The following is a description of a gene set: from publication Lund R, Aittokallio T, Nevalainen O, Lahesmaa R (PMID 14607935) Genes down-regulated in CD4 T cells activated by anti-CD3 and anti-CD28: TGFB1 and IL4 (2h) versus IL4 (2h). studied in species Homo sapiens Human Gene Set: GSE2770_TGFB_AND_IL4_VS_IL4_TREATED_ACT_CD4_TCELL_2H_DN Th1 and Th2 cells arise from a common precursor cell in response to triggering through the TCR and cytokine receptors for IL-12 or IL-4. This leads to activation of complex signaling pathways, which are not known in detail. Disturbances in the balance between type 1 and type 2 responses can lead to certain immune-mediated diseases. Thus, it is important to understand how Th1 and Th2 cells are generated. To clarify the mechanisms as to how IL-12 and IL-4 induce Th1 and Th2 differentiation and how TGF-beta can inhibit this process, we have used oligonucleotide arrays to examine the early polarization of Th1 and Th2 cells in the presence and absence of TGF-beta after 0, 2, 6 and 48 hours of polarization., and this is the list of marker genes: CUL3, WDR47, WASF3, CCL28, NAA15, INHBB, CAST, RAB2A, TMPRSS13, KRT33B, PRAMEF12, ANP32E, C18orf32, GAS2L2, MIER1, IL25, CD93, FRMPD2, APOF, VEGFD, PDE1A, SPINT4, CA5B, WAC, ERG, AGPAT5 (1-acylglycerol-3-phosphate O-acyltransferase 5), LSM5 (LSM5 homolog, U6 small nuclear RNA and mRNA degradation associated), PPP6C, PSMA4, KRT25, PGK2, SOS2, B3GNT6, AGFG1, PER2, POLE2, PUS7, DLX1, HS3ST3B1, LRFN1, PAM16, HRCT1, FOXL2, HMGCR, RNF186, FNDC5, MAMLD1, GTF2H5, SOCS6, STIM2, SNIP1 (Smad nuclear interacting protein 1), SLC2A13, SGCG, HRK, KCNK15, THBS3, MMGT1 (NCBI Gene Id 93380), DSCAM, TLCD3A, AFP, SESTD1, VWA7, DEFB116, ATP11C, FAM83G, C16orf74, ELP6, IP6K3, LRP8, PPIE, LIX1, UXS1, MIER3, SPACA4, ACADL, SBK1, S100A16, ANO4, MSMO1, F12, TINF2, AHR (aryl hydrocarbon receptor), FARP2, KLHL2, CNEP1R1, LHB, BNIP5, MARCHF3 (membrane associated ring-CH-type finger 3), HUS1, CDR2, ZNG1B, INAVA, VAT1L, CXADR, SRC, SLC25A16, TARDBP, LRRIQ4, ENSG00000285566, PDXP, CLTC, CAPZA2, SERBP1, RIPPLY3, GGT5, CALU, TIMM17B (NCBI Gene Id 10245), CEND1, ASIC5, SNPH, MIF, ENTPD1, SOCS3, DYNLT5, ALDH18A1, CSNK2A1, ZDHHC2, RNPS1, KCTD16, MAPK6, TGDS, EDEM1, MRAP2, ACSL4, GAN, SH3RF2, BCAP29, YWHAZ, SFTPC, CDH5, IL17RC, TM9SF3, VMA21 (vacuolar ATPase assembly factor VMA21), ERCC8, MED27, C4orf19, ORMDL3, UNC5C, PMCH, C9orf43 (chromosome 9 open reading frame 43), ARCN1, GPR35, CDCP1, SPTB, VIL1, ST3GAL6, GFM2, AMIGO1, UBFD1, DPH6, MPP4, EPHA4, JPH1, VPS36, B9D1, RIPK4, XPOT, KCP, ODC1, GUCA1B, PDCD5, CDKL2, ZNF462, INHBE, CMKLR2, PMVK, SPATA24, MPP2, RFK, RBSN, ACER3, SLIT3, FRA10AC1, IWS1, HK1, KCNT1, FAM156A, KNTC1, ERI1, NUP58, ANGPT2, TMEM209, ARMH3, RASAL1, CDR2L, CYP51A1, CRTC2, MRPS10, LATS1, PLCXD3, EMX2, BANF1, HOXD10, SLC13A5, HSPB7, MDH2, ART1, GADD45B, CHUK, C1orf105